The following is a description of a gene set: part of: DNA Replication studied in species Mus musculus electronically inferred by orthology from the curated human pathway Reactome Pathway: Strand-asynchronous mitochondrial DNA replication This event has been computationally inferred from an event that has been demonstrated in another species.<p>The inference is based on the homology mapping from PANTHER. Briefly, reactions for which all involved PhysicalEntities (in input, output and catalyst) have a mapped orthologue/paralogue (for complexes at least 75% of components must have a mapping) are inferred to the other species., and this is the list of marker genes: Polg2